Given this list of marker genes SEPHS1, NMU, HMGN5, SERTAD4, H1-0, C16orf74, KRT34, UCP2, PRKCA, CHMP4C, MATN2 (NCBI Gene Id 4147), N4BP2, NIPAL3, ESCO2, CLIC4, SCLY, TRAM2, XRCC4, MIF4GD, BAIAP2L1, SLC25A10, PHF21B, EPB41L3, C21orf91, DMKN, PPM1F, CCBE1, TMEM256, C14orf28, SNCA, HAUS4, BLTP3A, MAP3K20, ELAPOR1, MAOA, KCTD14, TNNT2, NCOA1, MTSS2, FBXO9, KMT2D, PDXK, MYL9, AP1M2, MYL2, GUCD1, BBX, SPCS3, ZNF252P, TAF9B, RAP2C, VDR, TGOLN2, DIS3L, AIF1L, MSI2, GNAI1, CDC42 (NCBI Gene Id 998, cell division cycle 42), MAGI2-AS3, PARD3, ZNF219, DHRS11, TCEAL2, ACAT2, DYRK4, ATPAF1, COL3A1, ST6GALNAC6, ITGB3BP, TSEN15, MED30, ZNF853, CYRIA, CHMP4A, TWF1, POM121, MN1, RGS9, ARIH2, NDFIP1, MICALL1, NPPB, TPGS2, CLPTM1L, ELFN2, GOLGA3, GSG1, CCDC85C, ZBTB26, PHLDA2, MON1B, LIMD1, H2AX, NDST1, UBE2I (NCBI Gene Id 7329), ANP32A, TRO, ZDHHC13, ATAD2, LINC02901, CEP41, PAK4, RIN3, ALDH5A1 (aldehyde dehydrogenase 5 family member A1), CDK16, SYNE1, TUG1, ALCAM, ATP13A3, PRKAG1, DOCK5, PDLIM1, DGCR2, UBE2Z, ENPP5, C1QL1, NOTCH3, KRTAP2-3, CARHSP1, MAGEA8, CSTA, KIAA0930, PCOLCE, MSTO1, NUDT21, SHOC1, NID1, SPC24 (SPC24 component of NDC80 kinetochore complex), FADS1, OTOGL, TGFB2, DAB2, BCL9L, SNX8, COL1A1, ZNF542P, BTBD2 (BTB domain containing 2), PLRG1, TEX2, ANKRD52 (ankyrin repeat domain 52), SNAPC1, NECAP1, DYNLL2, ENDOD1, SPX, CCN2, CDCA7L, TPM1 (NCBI Gene Id 7168), EXT2, KCNJ5-AS1 (NCBI Gene Id 219833), TRIM59, SDR42E1, FEM1B, CYP24A1, SLC2A10, FBXL16, MECP2, DIABLO, KIAA1143, RAB24, SLC7A5, FOXS1, FKBP9, GNG12, APOOL, EDN2, FANCG, BARD1, MIR1915HG, TMEM120B (NCBI Gene Id 144404), LINC01638, TNNC1, STMN3, COX20, UBE2K, CBS, HADH, MDFIC, PTK7, MFSD14B (NCBI Gene Id 84641), SLC25A43, CDC40, DHFR, TMEM243, MPP7, PCDH7, FLRT2, ADNP2, LIMCH1 (LIM and calponin homology domains 1), NFATC3, FOXO6, ARHGDIB, ANXA8, PPARD, SMARCC2, MRPL4, PLEKHA2, ZNF404, NSD3, FGD5-AS1, GBA1, VAMP8, COL8A1, GALNT10, GLIS2, GAS2L1, NCOR2, PRKD1, PDS5A, RAB11FIP1, DTNA (NCBI Gene Id 86552), CTR9, PEX2, TAX1BP1, FAM83H, BCAT1, PCLO (piccolo presynaptic cytomatrix protein), C9orf40, DCHS1, OLMALINC, GADD45B, IL1RAP, SEPTIN7, SAMD1, TMEM39B, ZCCHC24, SUN3, ABLIM1, MARCHF4, RNF213, BCL7B, C2CD5, TFDP1, TCF3, TMX3, MCM6, ZNF629, PTGFRN, ULK3, AJUBA, NME4, LOXL1-AS1, TNS3, PSMG2, RASA4, PAIP1, ORAI3, GPAT2, NOL4L, SLC16A7, DCAF7, SFTA1P, CYTH3, UFM1, JDP2, TBPL1 (TATA-box binding protein like 1), PSAT1, TMEM45A, FMC1, ZNF71, GCA, KIF14, HSD17B12, LBH, ZDHHC12, ASF1B, DGKZ, CXCL14, CXXC5, CLN6, TCF4, GSTT1, BRD7, DHRS2, PLAC1, TMEM40, MED20, SEH1L, ACSL3, VANGL2, MGAT5B, SYNPO (synaptopodin), PLP2, DFFA, RYBP, FKRP, ROCK2 (Rho associated coiled-coil containing protein kinase 2), NNT-AS1, MGAM, KATNBL1, ANTXR1, OIP5-AS1, NAB2, FAH, SLC25A23, NLRP1, CENPE, TOX3, TAGLN, ASNS, RAPH1, ANKRD9, C8orf88, CGNL1, BIRC5, ATG9A, EIF4EBP2, BNIP3L, SH3RF3, FBLN1, GABRB3, ZMYM4, EFCAB2, VSTM1, CASKIN2, LFNG, NFATC2IP, EPN2, SUV39H1, DNM1, PARD6G, FHOD1, IREB2, RAB3B, EIF4EBP1, MLXIP, NPM3, CTBP1 (NCBI Gene Id 1487), LINC02861, TCAF1, ENPP2, PLXND1, TTK, MFSD10, HDAC3, WDR6, CAVIN1, PIP4P1, TSPAN14, GCNT2, KHDC1L, MDP1, FGF1, NUP35, SCD, MCAM, DMAC2, PROSER2, NAA40, DSE, SCIN, PKP4, MARCHF6, IL27RA, KRT80, VEZF1, SLC24A1, EBI3, CYB5R3, SLX4IP, DYNLRB1, TUFT1, LRRC20 (NCBI Gene Id 55242), ENSG00000310059, CSNK2A2, EIF3E, NUP62CL (NCBI Gene Id 54830), GDAP1, BAIAP2-DT, KPNA6, PKP2, MARCHF8, TMCC1, ADGRL1, COL11A1, ADD3, UQCC3, LAT2, TLCD4, DAW1, RBMS3, TMEM37, STXBP6 (NCBI Gene Id 29091), UGGT1, ADGRB2, ARAP2 (NCBI Gene Id 23278, ArfGAP with RhoGAP domain, ankyrin repeat and PH domain 2), MAPK1, TXNRD2, MCM3AP, GCAT, TRIM6, BCAM, PPP1R14C, PATJ, ATMIN, FGF11, COL5A2, BRI3BP, GAP43, CEBPG, CEP20, SKIL, WFS1, YARS1, ABCA13, ZNF395, C4orf3, DPY19L2, DCTN4, EGR1, LMNB2 (NCBI Gene Id 84823), CTIF (NCBI Gene Id 9811), ITGBL1, FZD2, ADCY7, FIBP, TCP11L1, ANO2, VEZT, ANP32E, NF2, CCN1, LIN28B, YAP1, TGFB1I1 (NCBI Gene Id 94988), SAP30L, BACE2, ASXL1, UTRN, GTF2A1, TMEM255A, UNG, EMB, GFPT1 (glutamine--fructose-6-phosphate transaminase 1), RIMS2, GAS2L3, SDC2, MOV10, DERA, PDLIM2, TNS1, CDC25A, NANOS1, ATP5IF1, RGP1, FAM3C, RAB15, CRIM1, LGALSL, ORAI2, SMIM20, CTH, CHKA, TENM2, CFL2, DRAM2, MITF, LRRC47, COMMD8, NHSL3, KPNB1, GDPD5, GNE, HIP1R (huntingtin interacting protein 1 related), ALOX5, ZNF280B, AARS1, NACC2, PABPC4L, PGRMC2, CDR2L, TENT5B, ARSB, OGDHL, AHNAK, PHGDH, ZNF512B, TK1, GPX3, CCDC144NL-AS1, MYBL2, SEMA3B, C2orf68, OBSL1, MOB3B, TPM4, VGLL3, PIMREG, MNS1, BRPF3, TMED10, LRRC4C, VAC14, ILRUN, SFN, PSRC1, SCARA3, GOSR2 (NCBI Gene Id 9570), SEC62, PDHB, PCGF2, CASC3 (CASC3 exon junction complex subunit), LACTB, TSPAN31, PNMA2, FIGN, MRTFB, KATNB1, WFDC21P, TMED8, MISP, BEX1, EBP, SZRD1, CD99L2, CYB5B (NCBI Gene Id 80777), POGLUT3 (protein O-glucosyltransferase 3), UPF3B, EID1, NEU1 (neuraminidase 1), SPARC, ACAP2, NCKIPSD, BET1, TRMT5, EEA1, HEG1, SLC35A3, MYO5B, AEBP2, SLC39A14, ALDH3B1, LPAR5, CARM1, IFT80, ZNF70, HINT3, FES, MRPL58 (NCBI Gene Id 3396), ACKR3, NINJ1, PLAC8, ZNF559, VPS35, CDK19, NISCH, LINC02210, NFIA, NFASC (neurofascin), here is a description of the gene set: Human Gene Set: SENESE_HDAC3_TARGETS_DN Genes down-regulated in U2OS cells (osteosarcoma) upon knockdown of HDAC3 by RNAi. studied in species Homo sapiens Posttranslational modifications of core histones are central to the regulation of gene expression. Histone deacetylases (HDACs) repress transcription by deacetylating histones, and class I HDACs have a crucial role in mouse, Xenopus laevis, zebra fish, and Caenorhabditis elegans development. The role of individual class I HDACs in tumor cell proliferation was investigated using RNA interference-mediated protein knockdown. We show here that in the absence of HDAC1 cells can arrest either at the G(1) phase of the cell cycle or at the G(2)/M transition, resulting in the loss of mitotic cells, cell growth inhibition, and an increase in the percentage of apoptotic cells. On the contrary, HDAC2 knockdown showed no effect on cell proliferation unless we concurrently knocked down HDAC1. Using gene expression profiling analysis, we found that inactivation of HDAC1 affected the transcription of specific target genes involved in proliferation and apoptosis. Furthermore, HDAC2 downregulation did not cause significant changes compared to control cells, while inactivation of HDAC1, HDAC1 plus HDAC2, or HDAC3 resulted in more distinct clusters. Loss of these HDACs might impair cell cycle progression by affecting not only the transcription of specific target genes but also other biological processes. Our data support the idea that a drug targeting specific HDACs could be highly beneficial in the treatment of cancer. from publication Senese S, Zaragoza K, Minardi S, Muradore I, Ronzoni S, Passafaro A, Bernard L, Draetta GF, Alcalay M, Seiser C, Chiocca S (PMID 17470557)